Given this list of marker genes TNF, KLF5 (NCBI Gene Id 688), MIR29B1, MYF6, FOLR1, GATA1, VPS54 (VPS54 subunit of GARP complex), MATN2, MIR199A1, MED1, TNC, TMEM182, CAPN3, GAP43, UCP2, ANXA1, NEFL, MAP2K1, PDX1, TEC, ERBB4, GAS6, B4GALNT2, MMP2 (matrix metallopeptidase 2), APOA5, F7, PTPN12 (protein tyrosine phosphatase non-receptor type 12), CFLAR, IL6, IGFBP1, CPQ, PTPRF, KLF4, AKIRIN1, EYS, CD9, TARBP2, GFAP, NINJ2, HOPX, LCP1, IL10, PLG, MIR590, CCNA2, MAP1B, CCND1, JUN, MYOD1, TGFB1, WNT10B (Wnt family member 10B), SPP1 (NCBI Gene Id 6696), NOTCH1, MT-CYB, TOP1, MYMX, FGF10, CCNB1, KPNA1, FKRP, GPX1, HSPG2, UPF2, MIR221, ATIC, EPPK1, PTN, BAK1, ASCL3, RUNX1, FLT3, NFIB, GRN, CXCL12, DHFR, PPARD, PRRX1, ISL1, IFRD1 (NCBI Gene Id 95049), LRIG2, BAAT, YAP1, NREP, CERS2, NINJ1, DHFRP1, MAPK8IP3, CSNK2A2, RTN4RL1, GJD4, GLI1, FZD7, CCN3, SOX15 (SRY-box transcription factor 15), KIAA0319, JAK2, GATA4 (GATA binding protein 4), SCARF1, NTRK3, MDK, SRSF5, CTNNA1, FZD9, HDGFL2, ANGPT2, GUCD1, CD81, ULK1, XIRP1, CDKN1B, PUM2, WNT7A, IGF2R, PPP3CA, PRMT5, INPP5F, MYMK, CLDN1, CEBPA, RAP1A, PTGFRN, CAD, PTPRS, EPHA4, PNPT1, THY1, NACA, MIR431, MSTN (NCBI Gene Id 2660), BRAF, CDKN1A, GSTP1, KLK6, SRSF1, SELENON, MUSTN1, BIN3, PCNA, EZH2, APOA4, SPAAR, APOD, P2RX5, MIR222, ADAM17, PTPRU, SULF2, GNAT2, WNT1, IHH, DAG1, RPS15, LAMB2, PAX7, MCUB, BCL2, STK24, AURKA, PTCH1, KREMEN1, POSTN, RGMA, MTR, LARGE1, LPIN1, VTN, RTCA, LGR6, FIGNL2, RTN4R, MYOZ1, CPT1A, BCL9, MAP2K2, TM4SF4 (NCBI Gene Id 7104), GNAT1, ADAM15, TNR, DUSP10, CEBPB, NR0B2, COL6A1, IGF1, SOX2, NEO1, MAG, TSPO (NCBI Gene Id 706), SLC7A5, RTN4RL2, OMG, CNTF, TGFBR3, here is a description of the gene set: The regrowth of a lost or destroyed body part, such as an organ or tissue. This process may occur via renewal, repair, and/or growth alone (i.e. increase in size or mass). Human Gene Set: GOBP_REGENERATION studied in species Homo sapiens